The following is a description of a gene set: Human Gene Set: GOBP_REGULATION_OF_ASYMMETRIC_CELL_DIVISION species: Homo sapiens Any process that modulates the frequency, rate or extent of asymmetric cell division., and this is the list of marker genes: PAX6, WNT9B (Wnt family member 9B), INSC, ASPM, POU5F1